Given this list of marker genes PRR12, IMP3, RAB3A, MTMR3, FBXW7, CASP9, NEMP2, STARD9, TIGD2, THBD, LPAR5, MDC1, CYTH4, ZDHHC1, FES, MIDN, C5AR2, TBC1D14, DCTN5, FBXO21, OSBPL11, BAZ1B, BUB1B, PDCD7, DEF6, CD300LB, ARHGEF7, UMPS, GCNT1, SEPTIN7, HELQ, PLK3, HPS3 (NCBI Gene Id 85393), PCMTD1, RREB1, ERCC5, TMEM104, FAM193B, SLC35A5, VGLL4, R3HCC1, ZFAND2A (NCBI Gene Id 90637), HYLS1, GPR157, NEDD9, VPS26A, CLN8, CEP68, MTRF1L, COMMD5, SLC35A1, TBC1D2, CDCA7, TTC14, RUNX3 (NCBI Gene Id 864), NCOA3, IL21, IRF4, GRN, MPV17, GMNN, MIA2, ZBTB45, NIT2, IFFO2, NPAT, TMEM126B, TRMT12, H2AC4, AKAP7, CDC25B, OSGIN1, KBTBD7, TMEM106A, SLC25A35, GPR155, NFATC1, CFAP20, GPR146, AMACR, PPP1R13B (NCBI Gene Id 23368), TIFAB, WDCP, ADAMTS10, CUL9, ESCO2, POLD3, CCDC163 (CCDC163 homolog), PROKR1 (prokineticin receptor 1), TRAPPC14, ALMS1, TGFBRAP1, SNX8, SCLT1, ARHGAP25, TDP2, CROT, PSTK, CEP95, ARL4C, LACTB2, NFAM1, KIFC3, TWNK, XRCC6, CLIC1, TBL1XR1, NT5DC3, GRK2, ZBTB38, NKIRAS1, AP2A2, BRIP1, CD200R1, TUBGCP5, APOBEC1, BHLHE41, STARD8, PLEKHM1, REV3L, OPLAH, NDUFV3, MAGEF1, PRKRA, BLOC1S3, TMEM18, BTBD19, SNX2, BLOC1S2, MIS18BP1 (MIS18 binding protein 1), GAN, TMEM154, GCC2, POLG2, PRAM1, SOCS6, SMPD2, PROSER3, MSRB2, ELMOD2, PDPK1, NRROS, IRAG2, TBXAS1, SMYD4, GAB3, PPARGC1B, ZMYND8, PPCDC, HDAC10, ACER3, ELMO2, TBC1D31, ARL11, GTF2I, PPP1CC, TMEM218, AGA (NCBI Gene Id 175), SEPTIN10, NCOA1, LPAR6, CLIP2 (CAP-Gly domain containing linker protein 2), MAP3K9, SNX24, MYO1F, ID1 (NCBI Gene Id 96820), SLBP, UVRAG, XPC, here is a description of the gene set: An unresolved issue in immunology is the extent to which inflammatory effects are needed for robust T cell responses. In this study, mice were immunized by iv injection using either high toxicity lipopolysaccharide (LPS) or low toxicity monophosphoryl lipid A (MPL) as adjuvant. Six hours after iv immunization, whole spleens were harvested and gene expression was measured in unfractionated splenic populations of cells. The analysis indicated that the low toxicity adjuvanticity of MPL was associated with TLR4-mediated signaling that was biased to the TRIF branch of TLR4, while LPS generated balanced MyD88 and TRIF-associated outcomes. Human Gene Set: GSE7768_OVA_ALONE_VS_OVA_WITH_LPS_IMMUNIZED_MOUSE_WHOLE_SPLEEN_6H_UP Genes up-regulated in spleens from mice immunized with ova peptides alone versus those immunized with LPS as adjuvant. studied in species Homo sapiens from publication Mata-Haro V, Cekic C, Martin M, Chilton PM, Casella CR, Mitchell TC (PMID 17569868)